Given this list of marker genes TSPAN13, HOMER2, GJB1, TPD52L1, CHN2 (NCBI Gene Id 644086), GGNBP1, BCKDHA, SLC7A4, RASSF3, MANSC1, FAM234B, NR4A1 (nuclear receptor subfamily 4 group A member 1), ABCB6 (NCBI Gene Id 541461), UPB1, RAP1GAP, SPDEF (SAM pointed domain containing ETS transcription factor), CREB3L4, ATP1B1, C6orf58, GNE, CLDN2, ELAPOR1, LRRC26, ACSS1, TSPAN8, CPD, IQGAP2, SIDT1, CA6, TESC, MFSD4A, HLA-B, PPARGC1A, DHRS4, AASS, LIG3, HDAC11, NCALD, DHRS7, SMPDL3A, PIK3AP1, LMTK2 (lemur tyrosine kinase 2), BHLHA15, SLC31A2, BCL2L14 (BCL2 like 14), DDO, here is a description of the gene set: Human Gene Set: HOLLERN_MICROACINAR_BREAST_TUMOR_UP Human breast cancer has been characterized by extensive transcriptional heterogeneity, with dominant patterns reflected in the intrinsic subtypes. Mouse models of breast cancer also have heterogeneous transcriptomes and we noted that specific histological subtypes were associated with particular subsets. We hypothesized that unique sets of genes define each tumor histological type across mouse models of breast cancer. Using mouse models that contained both gene expression data and expert pathologist classification of tumor histology on a sample by sample basis, we predicted and validated gene expression signatures for Papillary, EMT, Microacinar and other histological subtypes. These signatures predict known histological events across murine breast cancer models and identify counterparts of mouse mammary tumor types in subtypes of human breast cancer. Importantly, the EMT, Adenomyoepithelial, and Solid signatures were predictive of clinical events in human breast cancer. In addition, a pan-cancer comparison revealed that the histological signatures were active in a variety of human cancers such as lung, oral, and esophageal squamous tumors. Finally, the differentiation status and transcriptional activity implicit within these signatures was identified. These data reveal that within tumor histology groups are unique gene expression profiles of differentiation and pathway activity that stretch well beyond the transgenic initiating events and that have clear applicability to human cancers. As a result, our work provides a predictive resource and insights into possible mechanisms that govern tumor heterogeneity. Genes that have high expression in mammary tumors of microacinar histology. from publication Hollern DP, Swiatnicki MR, Andrechek ER (PMID 29346386) species: Mus musculus